The following is a description of a gene set: studied in species Mus musculus Glucagon-like Peptide-1 (GLP1) regulates insulin secretion Mouse Gene Set: REACTOME_GLUCAGON_LIKE_PEPTIDE_1_GLP1_REGULATES_INSULIN_SECRETION, and this is the list of marker genes: Rap1a, Gng13, Gnb1 (guanine nucleotide binding protein (G protein), beta 1), Gnb5, Gngt2, Gng2, Itpr1, Gngt1, Itpr3, Rapgef4, Gng7, Prkaca, Kcns3, Prkacb, Gng8, Gnb4, Kcnc2, Gnb2, Gnb3, Kcng2, Gng11, Gnas, Rapgef3, Itpr2, Gng3, Gcg, Glp1r, Gng10, Gng5, Gng12, Gng4, Kcnb1